Given this list of marker genes TCF3, BCL2, SLAMF8, RAG2, TP53, PRKDC, here is a description of the gene set: studied in species Homo sapiens The process in which a lymphoid progenitor cell becomes committed to become any type of B cell. Human Gene Set: GOBP_B_CELL_LINEAGE_COMMITMENT